The following is a description of a gene set: part of: Chromatin organization Reactome Pathway: ATP-dependent chromatin remodelers studied in species Mus musculus electronically inferred by orthology from the curated human pathway This event has been computationally inferred from an event that has been demonstrated in another species.<p>The inference is based on the homology mapping from PANTHER. Briefly, reactions for which all involved PhysicalEntities (in input, output and catalyst) have a mapped orthologue/paralogue (for complexes at least 75% of components must have a mapping) are inferred to the other species., and this is the list of marker genes: H3c11, Ctnnb1, H2ac11, H2ac8, Pwwp2a, Mbd3l2, Mta2, H2bc15, H2ac4, Smarcc1, H3c6, H3f3a (NCBI Gene Id 15078), H4c17, H4c14, H3c2, Ss18l1, H2ac6, Ss18, H4c2, H2bc12, Bcl7b, H4c11, H2ac7, H4c4, Fam124b, H2bc1, H2bc7, Sumo1, Smarca4, H2bc8, H2ac19, Mbd2, H2ac20, Smarcd2, H4c6, Phf10, H3c7, Smarca2, H3c8, H2bc11, Arid1a, Smarcb1, Bcl7a, H2bc13, H2ax, Mta1, H2ac12, Zfp687, H3c1 (NCBI Gene Id 360198), H4c9, H2ac15, Bicral, Mbd3, Zfp532, H2ac1, H4c12, Chd8, Nr2c2 (nuclear receptor subfamily 2, group C, member 2), H2ac10, Rbbp7, H2ac22, Smarcd1, Smarcc2, H3c4, H4c8, H4c3, Rbbp4, H3c3, H2bc27, H2bc3, H2ac23, H2ac24, H3c15, H3c13, H2bc22 (NCBI Gene Id 319188), H4c18, Dpf1, H2bc9 (H2B clustered histone 9), H2az2, H4c1, H3c10, H2ac13